Given this list of marker genes UGT1A9, UGT3A1, UGT2B28, UGT1A7, UGT1A4, UGT1A5, UGT3A2, UGT1A8, UGT2B4, UGT1A1, UGT2B11, UGT2B15, UGDH, UGT2A1, UGT2B10, UGT1A10, SLC35D2, UXS1, ABHD10, UGT1A3, UGT2B7 (UDP glucuronosyltransferase family 2 member B7), UGT1A6, SLC35D1, UGP2, UGT2B17, UGT2A3, UGT2A2, here is a description of the gene set: part of: Phase II - Conjugation of compounds Glucuronidation conjugation utilizes UDP-glucuronosyltransferases (UGTs; EC 2.4.1.17) to catalyze a wide range of diverse endogenous and xenobiotic compounds. Glucuronidation is the major pathway in phase II metabolism and accounts for approximately 35% of drug conjugation. UGTs are microsomal membrane-bound and catalyze the transfer of a glucuronate group of uridine diphosphoglucuronate (UDPGA, a co-substrate) to the functional group of specific substrates. UDPGA is synthesized from glucose-1-phosphate (G1P). G1P is required for glycolysis and is present in high concentrations in the cell, making it is unlikely to be a limiting factor in UDPGA synthesis. UDP is added to G1P to form UDP-glucose which is then dehydrogenated to form UDPGA. The basic reaction is<p><b>UDP-Glucuronate + acceptor -> UDP + acceptor-beta-D-glucuronide</b></p>The effect of this conjugation is to confer polarity to the substrate which can then be easily excreted in urine or bile. Functional groups acted on include hydroxyl, carboxylate, amino and sulfate groups. There are 2 families of UGTs, UGT1 and UGT2 which are further sub-divided into 3 subfamilies, UGT1A, UGT2A and UGT2B. There are more than 26 different isozymes in humans, of which 18 are functional proteins. They are composed of 527-530 residues and have a molecular weight of 50-57KDa.<br>The UGT1 family comprises of 9 proteins (UGT1A1, 1A3-1A10) but only 5 have been isolated in humans. Example substrates which are glucuronidated are acetaminophen by UGT1A6 and bilirubin by UGT1A1. Members of the UGT2 subfamily are each encoded by their own genes, in contrast to UGT1As which are encoded at the UGT1 locus. Example substrates are morphine conjugation by UGT2B7 and androgenic steroid conjugation by UGT2B17.<br>Xenobiotics conjugated with glucuronic acid can be substrates for beta-glucuronidase, an enzyme common in gut microflora. This enzyme can release the parent or phase I metabolite which can be reabsorbed. It can then either re-exert it's original effects or be conjugated by glucuronic acid again. This cycle is called <i>enterohepatic circulation</i> and can delay the elimination of the xenobiotic. studied in species Homo sapiens Reactome Pathway: Glucuronidation